Given this list of marker genes CSF2RB (NCBI Gene Id 3564), SFTPA1, ABCA3 (NCBI Gene Id 21), SFTPC (surfactant protein C), SFTPB, SFTPA2, SFTPD, CSF2RA, SFTA3, SLC34A2, here is a description of the gene set: Human Gene Set: REACTOME_DISEASES_ASSOCIATED_WITH_SURFACTANT_METABOLISM species: Homo sapiens Diseases associated with surfactant metabolism